The following is a description of a gene set: Mouse Gene Set: GOCC_NUCLEAR_SPECK A discrete extra-nucleolar subnuclear domain, 20-50 in number, in which splicing factors are seen to be localized by immunofluorescence microscopy. studied in species Mus musculus, and this is the list of marker genes: Dennd1b, Hnrnpu, Ifi204, Tut1, Hspa1b, Nampt, Cdc34 (cell division cycle 34), Atp6v0a1, Pacsin2, Eapp, Hif3a, Zc3h18, Gatad2a, Srrm1, Gtf2h2, Msl1, Nme8, Kazn, Aipl1, Apbb1, Api5, Maml3, Tfip11, Hexim2, Ilrun, Rbm14, Nono, Cnot7, Mecom, Fam76a, Cop1, Mapk14, Sde2, Rsrc1, Phf7 (PHD finger protein 7), Hspb6 (NCBI Gene Id 407970), Cwc22, Bard1, Ell, Aff2, Cir1 (NCBI Gene Id 74817), Epas1, Srsf4, Ndc80, Apex1, Gadd45a, Ppp1r8 (NCBI Gene Id 230788), Chd5, Msx2, Sarnp, Cmya5, Mocs2, Sumo1 (NCBI Gene Id 22218, small ubiquitin-like modifier 1), Chrna3, Cdc5lrt4, Usp36, Hoxa6, Lhpp, Eftud2, Ruvbl1, Snrpb2, Thap7, Zbtb16, Ifi211, Nuggc, Ncbp3, Sf3b1, Parn, Cbx4, Sry, Hectd1, Carmil1, Nxf1, Bcas2, Atf4 (activating transcription factor 4), Cwc22rt1, Rfxap, Gli2, Heatr5b, Ik, Cdc34b, Marcks, Malat1, Thoc7, Arhgap18, Timm50, Grk5, Smu1, Cdc5l, Mtrex, Luc7l2, Cdc5lrt8, Snrnp70, Pla2g6, Unc45a, Npm1, Srp54a, Il16, Cdc5lrt7, Tbxa2r, Luc7l3, Ush1g, Arglu1, Atpaf2, Limk1, Cdk12, Prpf4b, Sgo1, Cdc5lrt6, Ckap4, Ccnb3, Uhmk1, Pou4f2, Cdc25c, Pomp, Ddx17, Prkaa1, Cwc22rt4, Rbm4, Trim69, Ddx5, Glis2, Dnaaf1, Kmt2e, Rad54l2, Pnisr, Srsf2, Rbm8a2, Gtf2h4, Rtel1, Wbp4, Sprtn, Dock1, Magoh, Hif1a, Sf3a3, Pak2, Topors, Dgkb, Nr0b1, Cwc22rt6, Habp4, Csnk1a1, Erbin, Gatad2b, Esx1, Basp1 (NCBI Gene Id 70350), Ddx46, Akap17b, Stk19, Hipk1, Trip12, Son, Ythdc1, Dyrk3, Cactin, Poldip3, Srpk1, Setd1b, Plrg1, Zfp830, Prpf6, Rbm4b, Dhx36, Patl1, Dgkz, Eif4e, Prpf8, Srsf6, Hspa1a, Adgrd1, Sgk1, Srek1, Rbm19, Acin1, Srsf7, Brd2, Pias1, Hsf4, Taf5l, Rpgrip1l, Rbm15, Eif4enif1, Eif4a3, Rbm8a, Snurf, Cwc22rt7, Ap5z1, Wac, Dusp11, Cxxc1, Thoc3, Pqbp1, Etaa1, Thoc1, Cygb, Cwc25, Wbp11, Ddx39a, Ccnl1, Ncapg2, Tap2, Ndufb1, Ppp1cc, Eaf1, Nsl1, Hdac4, Tmem237, Ppp4r3a, Zcchc12, U2af2, Rchy1, Cry2, Prpf40a, Ptprh, Alkbh5, Sfpq, Srsf11, U2af1, Zfp106, Epor, Pias3, Nr4a2, Fam76b, Poli, Il15, Dync2li1, Mbd1, Rexo4, Ehmt2, Cwc22rt5, Wt1, Psme4, Palb2, Sart3, Morf4l1, Bclaf1, Pip5k1a, Rufy1, Ascc2, Cdc5lrt9, Hbp1, Sel1l2, Srsf10, Treml1 (NCBI Gene Id 71326), Nrip1, Ell3, Toe1, Rbm27, Rbm15b, Prpf4, Smurf2, Nxt1, Abitram, Smc4, Afdn, Prpf3, Surf2, Srsf8 (NCBI Gene Id 245492), Rp9, Cdc40, Fam107a, Foxo4, Sap18b, Dach1, Pspc1, Myocd (NCBI Gene Id 214384), Fyttd1, Snrpa1, Clk2, Jade1, Oip5, Zfp217, Alyref, Sf3b2, Prpf31, Sart1, Bnip3l-ps, Srsf9, Nup43, Nfatc4, Mns1, Prpf19, Eaf2, Mettl3, Nrde2, Ppp4r3b (protein phosphatase 4 regulatory subunit 3B), Inppl1, Slc28a1, Tab1, Lpxn, Atoh8, Noc3l, Tmem179b, Cwc22rt2, Dnajc11, Tcim, Sap130, Thoc6, Gpatch2, Prcc, Crnkl1, Cwc15, Fev, Cdc5lrt5 (cell division cycle 5 like, retrotransposed 5), Ddx39b, Iqch, Gli3, Dhx15, Wtap, Smc5, Nr4a1, Fastk, Aagab, Kif22, H2ax, Tcf12, Zc3h13, Thrap3, Nr3c1, Cd2bp2, Cops4, Ubash3a (ubiquitin associated and SH3 domain containing, A), Lmna, Prpf18, Pdx1, Radx, Fto, Sirt7, Mapt, Kat6a, Phf5a, Rbm25, Cdc5lrt1, Fam193b, Sf3a1, Zc3h14, Casc3, Pin1, Nsrp1, Ppih, Ccnl2, Akap8l, Zbtb18, Scaper, Srsf3, Baz2a, Pabpn1, Ylpm1, Ppp1r16b, Atxn2l, Ogg1 (NCBI Gene Id 18294), Vps72, Sfmbt2, Spop, Ddx42, Snrnp40, Pskh1, Hdac5, Tert, Cdc5lrt10, Syf2, Sdcbp2, Cdyl, Smc6, Fibp, Wrn, Polr2d, Zfp395, Cpsf6, Itpkc, Gcat, Dzip1, Zfp638, Meox2 (NCBI Gene Id 17286), Rbbp6, Prpf40b, Rbm10, Srrm2, Dyrk1a, Ring1, Cacnb4, Rnps1, Rbm39, Srsf1, Bmp2k, Prkaca, Prx, Ep400, Ctr9, Tenm1 (NCBI Gene Id 630184), Adamts4, Prkaa2, Hikeshi, Serpinb13, Mef2c, Nek6, Maml1, Gm4275, Prkn, Fbxl4, Klf15, Hspb3, Slu7, Rnu6, Pasd1 (NCBI Gene Id 382221), Tardbp, Adar, S100pbp, Ar, Cdk13, E2f7, Slc34a1, Rmi2, Ppihl, Virma, Cby1, Arl6ip4, Bnip3l, Abhd17a, Nr1h4, Snw1, Smndc1, Cwc22rt3, Scnm1, Grcc10, Ppie, Chtop, Hp1bp3, Ppig, Rreb1, Plcb1, Ascc3, Srpk2, Rnf34, Sf3a2, Cbx2, Rbm11, Cbll1, Setd1a, Dgkq, Pias2, Mapk9, Pcbp1, Thoc2, Ascc1, U2af1l4 (NCBI Gene Id 233073), Brd1, Mbd4, Nfkbiz, Pnn, Plag1, Sap18, Dazap2, Ak6, Fancg, Srsf5